The following is a description of a gene set: from publication Chen Y, Wang X (PMID 31504780) Genes predicted to be targets of miRBase v22 microRNA mmu_miR_6403 in miRDB v6.0 with MirTarget v4 prediction scores > 80 (high confidence targets). studied in species Mus musculus Mouse Gene Set: MIR_6403, and this is the list of marker genes: Zfp1009, Qki, Zfp951, Praf2, Ptp4a1 (protein tyrosine phosphatase 4a1), Dip2c, Sdc2, Cdk7, Rps6ka6, Dppa4, Hspb2, Ark2c, Zfp976, Mef2a, Dnah17, Erbin, Hbq1b, Nsun2, Ar, Aak1, Gm14391, Zfp609, Phf8, Gm14296, Csnk1d, St3gal1, Tead1, Mier1, Adrb3, Septin11, Cdc14b, Amer2, Parp16, Gm14308, 1700066M21Rik, Hoxb1, Cftr, Luc7l3, Bcor, Mal2, Mcrs1, Miga1, Ubr5, Epha1, Ssb, Tnks1bp1, Fnbp1, Atl3, Cacna1h (NCBI Gene Id 58226), Vegfa, Camkmt, Samhd1, Actg1, Zfp120, Myo19, Rap2c, Ovol1, Gmfb, Ttc12, Rfx4, Gsn, Tjp2, Fzd4, Ppp3ca, Gmcl1, Zdhhc6, Tfdp2, Lbp, Srgap2, Ttbk2, Acsl4, Mrtfb, Gm6710, Hdac9, Fam163a, Creb5, Zfp975, Nkain3, Kif3a, Sh3pxd2a, Tfap4, Acbd3, Vat1, Plagl1, Iqgap1, Tmed10, Gm5591, Uox, Dsel, Cldn34b4, Pcmt1, Slc30a7, Grb2, Cacnb4, Atp1b4, Nfib, Ankrd63, Pogz, Gng10 (guanine nucleotide binding protein (G protein), gamma 10), Capn7, Them7, Gpr158, Mphosph6, Zswim6, 2310057J18Rik, Noct, Ddx31, Wif1, Far1, Khdc1b, Slc17a2, Zfp971, Cep55, Prkab2, B4galt1, Sec22a, Neurod2, Sp110, Hebp2, B230219D22Rik, Ilf3, Pi15, Onecut3, Dnaaf4, Man1b1, Cpeb3, Emc10, Shc1, Map3k9, Ammecr1 (AMMECR nuclear protein 1), Pak3, Adgrg2, Mtmr10, Rab11fip1, Upp2, Stau1, Atxn7, Rheb, Rps6ka4, Tnfrsf1b, Manbal, Fras1, Sumf1, Prpf3, Aldh1l2, Zfp930, Csgalnact1, Rbbp7, Lats2, Cnpy3, Polr1c, D630045J12Rik, Zfp781b, Stox2, Abr, Fam133b (family with sequence similarity 133, member B), Nek7, Prkg1, Mmp16, Evi5, Gata6, Znrf3, Anks1 (NCBI Gene Id 224650), Cdc42se2, Ankrd12 (NCBI Gene Id 224959)